The following is a description of a gene set: species: Homo sapiens The chemical reactions and pathways involving low-density lipoprotein receptors. Human Gene Set: GOBP_LOW_DENSITY_LIPOPROTEIN_RECEPTOR_PARTICLE_METABOLIC_PROCESS, and this is the list of marker genes: ABCA2, PCSK9, FURIN, APOE, ANXA2, MYLIP